Given this list of marker genes HLA-DRB4 (major histocompatibility complex, class II, DR beta 4), H2AC16, PNISR, CSH1, FMR1, CD19, TCL1B, SH3TC1, H2AC6, TOP2B, IL7R, NSMF, H2BC10, BANK1, PTPRK, RUBCNL, TOP2A, KDM5D, CD24P2, BTG1, RAG1, STAG3, CHD7, P2RY14, RASL10A, IRF2, AK1, CD79B, BLK, CXCR4, LEF1, RAD52, PXDN, SPPL2B, TMCC1, PKD2, TASOR2, TCF4, H2BC5, SECISBP2L, EFHC1, ING1, SCHIP1, NEIL1, VAMP1, HS3ST1, MZB1, TOB1, ZBTB10, UGCG, MEF2A, FJX1, FCMR, H1-2, USP34, GSDMB, CD79A, PSD3, ABCG2, CAPN3, LILRB2, C6orf62, GPM6B, EIF1AY, PIK3CD, CITED2, ENTPD4, VSIG10, ELL3, RCBTB1, MME (membrane metalloendopeptidase), CRIM1, LRP2BP, RRM2, SLC35D1, ELK3, ZHX2, CEP135, DDX3Y, P2RX5, ATM, BTG2, DACT1, ELF2 (NCBI Gene Id 1998), FAM171A1, RETREG1, PCNA, HMCES, PRDM2 (NCBI Gene Id 82680), RFC5, DNTT, GADD45G, HMHB1, HMGB2, SNN, ANKRD10, RB1, RIMS3, MLXIP, POU4F1, CD69, SMARCA4, H3C4, H2BC7, WFS1, EFNB2 (NCBI Gene Id 1948), OR7A5, GLRX, GNG7, IRF4, PPFIBP1, VPREB1, COBL, H2BC9, PLEKHF2, PKN2, ISG20, CACNB3, SOD2, SMAD1-AS2, CDKN1B, PPM1A, CALM1 (NCBI Gene Id 801), ZFYVE16 (zinc finger FYVE-type containing 16), CTBP2 (C-terminal binding protein 2), ITPR1, AP1B1, LMF1, DNAJB14, TUBA4A, MS4A1, KCNJ2, BARD1 (NCBI Gene Id 580), AUTS2, P4HA2 (prolyl 4-hydroxylase subunit alpha 2), SNX2, SPANXA1 (sperm protein associated with the nucleus, X-linked, family member A1), CD27, IRAG2, ATR, MSX1, RNFT2, EIF2AK3, FHIT, DBN1, ZFP36L1, TTC13, MICU2, ANAPC5, DEPP1, ZNF177, KIF13A, E2F5, KAT2B (NCBI Gene Id 8850), LONP2, LDLRAD4 (NCBI Gene Id 753), GH1 (NCBI Gene Id 2688), PSPC1, CD24P4, RAG2, LAPTM5, TPD52, H4C8, BACH2, VPREB3, ENSG00000293341, HPS4, WASHC4, TRIB2 (tribbles pseudokinase 2), PVRIG, IGLC2, DDR1, TRIM38, SPTA1, HCP5, TTTY14, COL5A1, NPY, TMEM243, CD72, SNTB2, TLE1, IGF2R, GSAP, KMT2A, HRK, EZR, PPP3CC, ARID5B, IRS2 (NCBI Gene Id 90066), N4BP2L2, LILRA2, TLE4, BLNK, CORO2B, CHST15, LRIG1, ZNF160, PTPRE, DUSP26, TGIF1, KMT5B, MAGED4B, RBM6, LBH, SYNE3, DCK, PPM1B, ARHGEF7, TSPAN14, CD24, STK38, ADGRA3, TCF3, PLXNA2, ID3, MOG, TCL1A, HIP1R, ZNF107, ARAP2, MEF2C, ZMYM2, CD22, ATAD2B, QRSL1, DCP2, AEBP1, H1-4, CSGALNACT1, JADE2, PCBP2, JMJD1C, HLA-F, DLEU2, ZSCAN16, SSBP2, NID2, ARPP21, RB1CC1, H3C10, POU2AF1, ZNF423, RHOB, MPPED2, CIITA, PLXNA1, CCDC81, IGLL1, SEMA6A, TIA1, MDM1, TXLNGY, CDKN2C, CDK13, MSANTD2, GABPB1-IT1, RASGRP1, FOXO1, UXS1, TCL6, DNASE2B, ALDH5A1, PDS5B, FAM193B, AGFG1, SOCS2, ALOX5, MYLK, JUN, BTN2A1, CYFIP2, CAV1, PCDH9, REXO2, VPS13A, SMAD1, H4C2, DYRK2, EDEM1, PAX5, MAP4K4, TMEM131L, SCN3A, ZNF135, ZMYM5, AKAP12 (NCBI Gene Id 9614), VDAC1, CD9, SIAH2, here is a description of the gene set: The early stages of human lymphopoiesis are poorly characterized. Here, we compared the lymphoid potential of a novel umbilical cord blood CD34(+)CD45RA(hi)CD7(+) hematopoietic progenitor cell (HPC) population with that of CD34(+)CD45RA(hi)Lin(-)CD10(+) HPCs, previously proposed as candidate common lymphoid progenitors. Limiting-dilution and clonal analysis, fetal thymic organ cultures, and culture onto Notch ligand Delta-like-1-expressing OP9 cells, showed that although CD34(+)CD45RA(hi)CD7(+) HPCs could generate cells of the 3 lymphoid lineages, their potential was skewed toward the T/natural killer (T/NK) lineages. In contrast, CD34(+)CD45RA(hi)Lin(-)CD10(+) HPCs predominantly exhibited a B-cell potential. Gene expression profiling with DNA microarrays confirmed that CD34(+)CD45RA(hi)CD7(+) HPCs selectively expressed T-lymphoid and NK lineage-committed genes while retaining expression of genes affiliated to the granulomonocytic lineage, whereas CD34(+)CD45RA(hi)Lin(-)CD10(+) HPCs displayed a typical pro-B-cell transcription profile and essentially lacked genes unrelated to the B lineage. In addition, both populations could be generated in vitro from CD34(+)CD45RA(int)CD7(-) and CD34(+)CD45RA(hi)Lin(-) HPCs with mixed lymphomyeloid potential, from which they emerged independently with different growth/differentiation factor requirements. These findings indicate that CD34(+)CD45RA(hi)CD7(+) and CD34(+)CD45RA(hi)Lin(-)CD10(+) HPCs correspond to multipotent early lymphoid progenitors polarized toward either the T/NK or B lineage, respectively. from publication Haddad R, Guardiola P, Izac B, Thibault C, Radich J, Delezoide AL, Baillou C, Lemoine FM, Gluckman JC, Pflumio F, Canque B (PMID 15331438) studied in species Homo sapiens Human Gene Set: HADDAD_B_LYMPHOCYTE_PROGENITOR Genes up-regulated in hematopoietic progenitor cells (HPC) of B lymphocyte lineage CD34+CD45RA+CD10+.